The following is a description of a gene set: species: Homo sapiens Reactome Pathway: CDK-mediated phosphorylation and removal of Cdc6 As cells enter S phase, HsCdc6p is phosphorylated by CDK promoting its export from the nucleus (see Bell and Dutta 2002). part of: Switching of origins to a post-replicative state, and this is the list of marker genes: PSMD14, PSMC1, ANAPC15, PSMD8, PSMD12, FZR1, CCNA2, ANAPC2, PSMA2, RPS27A, CDC6, PSMA7, CDC23, PSMC6, UBE2S, ANAPC10, UBC, PSMA4, PSMA3, PSMD1, UBE2D1, CCNE2, PSMB3, UBA52, PSMD3, UBB, ANAPC1, CCNA1, PSMB5 (NCBI Gene Id 5693), PSMD6, ANAPC11, PSMD2, UBE2C, SEM1, PSMD13, PSMB7, PSMC4, PSMD11, PSMA1, PSMB2, PSMD7, ANAPC5, PSMB4, ADRM1, PSMB1, CDC27, CDC16, PSMC5, ANAPC16, PSMA5, ANAPC4, PSMA6, PSMC2, CDK2 (NCBI Gene Id 1017), PSMC3, UBE2E1, ANAPC7, CCNE1, CDC26, PSMB6